The following is a description of a gene set: part of: Signaling by NOTCH1 in Cancer Human NOTCH1 was cloned as a chromosome 9 gene, translocated to the T-cell beta receptor (TCBR) promoter on chromosome 7 in T-cell acute lymphoblastic leukemia (T-ALL). The translocated gene was found to be homologous to Drosophila Notch, and was initially named TAN-1 (translocation-associated Notch homolog). Although the translocation t(7;9)(q34;q34.3) is present in a small percentage of T-ALL patients, the mutant protein is highly oncogenic and its overexpression causes T-ALL-like illness in mice. Reactome Pathway: Signaling by NOTCH1 t(7;9)(NOTCH1:M1580_K2555) Translocation Mutant studied in species Homo sapiens, and this is the list of marker genes: DLL1, JAG2, ADAM17, JAG1, ADAM10, NOTCH1, DLL4